The following is a description of a gene set: Combining with an extracellular amine and transmitting the signal across the membrane by activating an associated G-protein; promotes the exchange of GDP for GTP on the alpha subunit of a heterotrimeric G-protein complex. species: Mus musculus Mouse Gene Set: GOMF_G_PROTEIN_COUPLED_AMINE_RECEPTOR_ACTIVITY, and this is the list of marker genes: Taar9, Taar6, Adrb1, Hrh1, Htr7, Taar8b, Chrm2, Adra1d, Hrh4, Adra2a, Taar4, Taar1, Adra2c, Chrm3 (cholinergic receptor, muscarinic 3, cardiac), Htr4, Adra1a, Hrh3, Htr6, Taar5, Taar8a, Htr1a, Adrb2, Taar8c, Htr5b, Htr1b, Htr2b, Taar7b (NCBI Gene Id 276745), Htr2c, Taar7a, Taar3, Taar2, Chrm5, Chrm1, Htr2a, Taar7e, Gpr88, Adra2b (adrenergic receptor, alpha 2b), Chrm4, Taar7f, Adrb3, Drd4, Adra1b, Hrh2, Htr1d, Htr5a, Taar7d, Htr1f